The following is a description of a gene set: Reactome Pathway: DAG and IP3 signaling studied in species Mus musculus part of: Intracellular signaling by second messengers This event has been computationally inferred from an event that has been demonstrated in another species.<p>The inference is based on the homology mapping from PANTHER. Briefly, reactions for which all involved PhysicalEntities (in input, output and catalyst) have a mapped orthologue/paralogue (for complexes at least 75% of components must have a mapping) are inferred to the other species. electronically inferred by orthology from the curated human pathway, and this is the list of marker genes: Adcy7, Camkk2, Prkcg, Prkca (NCBI Gene Id 18750), Prkaca, Adcy8, Adcy5, Pde1b, Prkar1b (protein kinase, cAMP dependent regulatory, type I beta), Calm1, Pde1c, Camkk1, Prkacb, Prkar2b